The following is a description of a gene set: species: Mus musculus Activation of IRF3, IRF7 mediated by TBK1, IKKε (IKBKE) Mouse Gene Set: REACTOME_ACTIVATION_OF_IRF3_IRF7_MEDIATED_BY_TBK1_IKK_IKBKE, and this is the list of marker genes: Optn, Uba52rt, Traf3, Irf3, Tank, Ly96, Ticam2, Irf7, Rps27a, Ticam1, Tbk1, Uba52, Sarm1, Ubc (ubiquitin C), Ikbke, Tlr4, Cd14, Ptpn11, Ubb